Given this list of marker genes SNRPB, LSM11, ERI1, YBX1, SYNCRIP, SLBP, here is a description of the gene set: studied in species Homo sapiens A ribonucleoprotein that binds to specific sites in, and is required for cleavage of, the 3'-end of histone pre-mRNAs. The complex contains the U7 snRNP and additional proteins, including the stem-loop binding protein (SLBP) and the exonuclease 3'hExo/Eri-1. Human Gene Set: GOCC_HISTONE_PRE_MRNA_3_END_PROCESSING_COMPLEX